Given this list of marker genes GNAQ, KRIT1, CCM2, PDCD10, PIK3CA, here is a description of the gene set: Choroidal hemangioma The presence of multiple hemangiomas in the choroid. These are generally reddish or orange or can have increased pigmentation maiking them difficult to distinguish from choroidal melanomas. studied in species Homo sapiens Human Gene Set: HP_CHOROIDAL_HEMANGIOMA